The following is a description of a gene set: studied in species Mus musculus Mouse Gene Set: GOBP_UREA_METABOLIC_PROCESS The chemical reactions and pathways involving urea, the water soluble compound O=C-(NH2)2., and this is the list of marker genes: Agmat, Otc, Nr1h4, Ass1, Asl, Arg2, Htt (NCBI Gene Id 319350), Nags, Cps1, Fh1, Cebpa, Arg1